Given this list of marker genes Plin2, Lipe, Aldh2, Itga7, Gpx4, Mnt, Agt, Fabp4, Ghr, Pcx, Acadvl, Gclm, Acads, Adrb3, Cfd, Pparg, Cox8a, Igf1, Pdha1, Vldlr, Ldhb, Stat5a, Scp2, Ddit3, Scd2, Ldha, Stat1, Ppa1, Vegfa, Vegfb, Fasn, Gadd45a, Adipoq, Cidec, Crat, Sqstm1, Cd36, Cpt2, Sparcl1, Acsl1, Pmp22, Anapc1, Bckdha, Stat3, Apoe, Mcl1, Fabp5, Cebpb, here is a description of the gene set: studied in species Mus musculus PPAR gamma is an adipocyte-specific nuclear hormone receptor. Agonists of PPAR gamma, such as thiazolidinediones (TZDs), promote adipocyte differentiation and have insulin-sensitizing effects in animals and diabetic patients. Affymetrix oligonucleotide arrays representing genes were employed to profile the gene expression responses of mature 3T3-L1 adipocytes and differentiating preadipocytes to a TZD PPAR gamma agonist in vitro. The expression of genes was significantly up- or down-regulated by more than 1.5-fold during differentiation and/or by treatment with TZD, and these genes were organized into 32 clusters that demonstrated concerted changes in expression of genes controlling cell growth or lipid metabolism. Quantitative PCR was employed to further characterize gene expression and led to the identification of beta-catenin as a new PPAR gamma target gene. Both mRNA and protein levels for beta-catenin were down-regulated in 3T3-L1 adipocytes compared with fibroblasts and were further decreased by treatment of adipocytes with PPAR gamma agonists. Treatment of db/db mice with a PPAR gamma agonist also resulted in reduction of beta-catenin mRNA levels in adipose tissue. These results suggest that beta-catenin plays an important role in the regulation of adipogenesis. Thus, the transcriptional patterns revealed in this study further the understanding of adipogenesis process and the function of PPAR gamma activation. Mouse Gene Set: GERHOLD_ADIPOGENESIS_UP from publication Gerhold DL, Liu F, Jiang G, Li Z, Xu J, Lu M, Sachs JR, Bagchi A, Fridman A, Holder DJ, Doebber TW, Berger J, Elbrecht A, Moller DE, Zhang BB (PMID 12021175) Selected genes up-regulated during differentiation of 3T3-L1 cells (fibroblast) into adipocytes in response to adipogenic hormones.